Given this list of marker genes VIL1, PLS1, EZR, CDHR5, CDHR2, USH1C, TWF2, here is a description of the gene set: studied in species Homo sapiens A process that modulates the length of a microvillus. Human Gene Set: GOBP_REGULATION_OF_MICROVILLUS_LENGTH